Given this list of marker genes GATA1, ALAD, KRT14, VCP, JAK2, NAGLU, OPA3, GRIN2A, SCN1A, MUTYH, KCNJ1, EPCAM, COMP, GNAS, PMS2, SEMA4A, HLA-DRB1, LMX1B, C4A, TGFBR2, CLCNKB, MEFV, PMS1, HPDL, AIP, SMARCB1, FAS, COQ6, POLD1, CUBN, TET2, CHEK2 (NCBI Gene Id 11200, checkpoint kinase 2), SLC26A2, IFNGR1, SERPING1, IL12A, THPO (NCBI Gene Id 84434), TRAPPC2, BRCA2, SLC12A3, IL12A-AS1 (IL12A antisense RNA 1), ADAMTS15, STX16, P4HA2, PRNP, IL23R, KIF5A, NEFL, SCN9A, GABRG2, MFN2, SRPX2, CTDP1, GPR101, NPRL3, VWA1 (von Willebrand factor A domain containing 1), CALR, NAGA, GBE1, LIG3, CCR1, UBAC2, ERLIN2, LIFR, CCM2, POLE, GLA, TLR4, HLA-DQB1, SCYL1, SLC12A1, MEN1, POLG, LITAF, GNA11 (G protein subunit alpha 11), PMP22, ATP1A2, NPRL2, HLA-B, HINT1, ATXN1, TYMP, CACNA1A, MSH2, CBLIF, PTPN22, TP53, KRAS, TRIM32, MPL, STAT4, SBF2, ATL1, SH2B3, MSH6, RRM2B, TNFRSF1A, BMPR1A, UROD, ATM (ATM serine/threonine kinase), MLH1, SCN4A, HEXB, SLC2A1, KRT5, PIK3CA (NCBI Gene Id 5290), GALC, SLC19A2 (NCBI Gene Id 7826), LZTR1, ERAP1, PDCD10, KLRC4, CASR, SEPTIN9, TK2, GNA14 (G protein subunit alpha 14), HMBS, APP, UROS, CCND1, MTHFR, NF2, DEPDC5, SPTLC2, RPS20, KRIT1, IL10, YY1, PRRT2, here is a description of the gene set: Paresthesia Human Gene Set: HP_PARESTHESIA Abnormal sensations such as tingling, pricking, or numbness of the skin with no apparent physical cause. species: Homo sapiens